The following is a description of a gene set: Mouse Gene Set: GOBP_HYPOXANTHINE_METABOLIC_PROCESS studied in species Mus musculus The chemical reactions and pathways involving hypoxanthine, 6-hydroxy purine, an intermediate in the degradation of adenylate. Its ribonucleoside is known as inosine and its ribonucleotide as inosinate., and this is the list of marker genes: Xdh, Ada, Prps1, Urah, Hprt1, Urad, Uox